Given this list of marker genes SDCCAG8, CA5B, SMARCD2, LXN, KIAA1143, PLD3, SUOX, TSR3, LGALS1, CTSD, SMIM11, TMEM230, MOSPD2, MLLT3, CYLD, ASL, BIN1, CAPZB, MANEA, GGH, CCDC107, RIOK3, LATS2, ARPC5, SGK1, TAFAZZIN (tafazzin, phospholipid-lysophospholipid transacylase), SLC10A7, RIPK1, CHMP5, OAZ2, LAPTM5, CHCHD6, RNF43, PKP2, PGLYRP1, COPE, DDIT4, DMAC1, GBE1, TRIM13, PHF8, SGF29, ETFA, TGDS, UFL1, S100A13, IFT80, PFN2, HTR2C, NDUFA7, FXYD5, TMEM14A, DNAJC18, ABHD5, CAB39L, FERRY3, RNF14, OFD1, NUDT2, RHOC, NDUFB3, COA3, ATP5F1D, SLC52A3, SIDT1, CLCC1, EAPP, FAM177A1, DHRS1, OMA1, DNAI4, GNPTG, ICAM2, COG5, DUBR, RPS11, GNS, PTPRCAP, LAT2, HERPUD2, NDUFAF7, PPP3R1, PSEN2, DPY30 (NCBI Gene Id 84661), YWHAH, HINT3, ILK, FAM174B, LRRC45, HEMGN, C11orf54, ATPSCKMT, ACP6, ITGB3 (NCBI Gene Id 3690), CMC1, MGRN1, FAM234A, BBLN, FUNDC1, S100A11, SERHL2, CCDC91, TRPV2, MMAA, NDUFB5, GTF2A2, RRAGC, COQ9, PPP2R2C, RBBP9, PCYT2, PXK, TMEM62, NAB1, UBTD1, UBASH3A, ANXA4, TRIM45, ATOX1, PKP3, DGKZ, RAB32, EHHADH, KHDC1L, RETREG1, RAB28 (RAB28, member RAS oncogene family), CWF19L2, SH3BGRL3, FLOT2, PDCL3, CYP4V2, FRA10AC1, AP5M1, UQCRB, ARHGAP18, ABCB9, KIFAP3, LCK, DNAJC12, PDLIM5, COTL1, CHPT1, MGAM, TMEM242, PAN3, SESN3, SLA2, FNDC4, CREB3L1, CD14, CYRIB, RABAC1, VPS37B, TBRG1, EMC2, ADSS1, BASP1, TMEM9B, CASD1, PLS3, ZC2HC1A, IL27RA, VTI1B (NCBI Gene Id 10490), TCEANC, AP4B1, CD37, CDPF1, PDCL, NSD3, MLF1, DNAJC10, EHBP1L1, S100A6, CERS4, EIF5A2, DGLUCY, SYAP1 (synapse associated protein 1), ZNF318, MAP2K5, EXOC6B, ACTR3, GIPC2, CRYBG1, RASGRP1, MTMR1, ACAT1, C1GALT1, C3orf33, SGPP1, NDUFA13, ABCB10, RAB1B (NCBI Gene Id 81876), IKBKG, CD200R1L, LRPAP1, UBXN11, TIMM29, TRAPPC2B, DSEL, ENTPD1, here is a description of the gene set: from publication Hinrichs CS, Borman ZA, Cassard L, Gattinoni L, Spolski R, Yu Z, Sanchez-Perez L, Muranski P, Kern SJ, Logun C, Palmer DC, Ji Y, Reger RN, Leonard WJ, Danner RL, Rosenberg SA, Restifo NP (PMID 19805141) studied in species Homo sapiens Effector cells for adoptive immunotherapy can be generated by in vitro stimulation of naïve or memory subsets of CD8+ T cells. While the characteristics of CD8+ T cell subsets are well defined, the heritable influence of those populations on their effector cell progeny is not well understood. We studied effector cells generated from naïve or central memory CD8+ T cells and found that they retained distinct gene expression signatures and developmental programs. Effector cells derived from central memory cells tended to retain their CD62L+ phenotype, but also to acquire KLRG1, an indicator of cellular senescence. In contrast, the effector cell progeny of naïve cells displayed reduced terminal differentiation, and, following infusion, they displayed greater expansion, cytokine production, and tumor destruction. These data indicate that effector cells retain a gene expression imprint conferred by their naïve or central memory progenitors, and they suggest a strategy for enhancing cancer immunotherapy. Genes up-regulated in comparison of rested memory CD8 T cells from pmel-1 mice versus rested naive CD8 T cells from pmel-1 mice. Human Gene Set: GSE16522_MEMORY_VS_NAIVE_CD8_TCELL_UP